Given this list of marker genes Zfpm2, Nucb2, Fermt2, Ptgr3, Gper1, Ankrd26, Ncor2, Tgfb1, Wnt1, Trpv4, Enpp1, Gata2, Tlcd3b (NCBI Gene Id 77785), Wnt5a, Bbs12, Gps2, Wwtr1, Wnt10b, Tgfb1i1, Lrp6, Yap1, Tcf7l2, Mkx, Smad3, Sirt2, Msx2, Insig1, Runx1t1, Mir448, Foxo1, Adipoq, Bmp2, Ddit3 (DNA-damage inducible transcript 3), Dlk1, Sod2, Zfp36l2, Axin1, C1ql4, Sort1 (sortilin 1), Tnf, Lrp3, Trib2 (tribbles pseudokinase 2), Trib3, Jdp2, Jag1, Flcn, Rora, Bmal1, Trio, Fbn1, Slc7a10, Wnt3a, E2f1, Asxl1, Ccdc85b, Sirt1, Vegfa, Id4, Ccn4, Mmp11, here is a description of the gene set: studied in species Mus musculus Any process that stops, prevents, or reduces the frequency, rate or extent of adipocyte differentiation. Mouse Gene Set: GOBP_NEGATIVE_REGULATION_OF_FAT_CELL_DIFFERENTIATION